The following is a description of a gene set: Estrogen-dependent nuclear events downstream of ESR-membrane signaling Human Gene Set: REACTOME_ESTROGEN_DEPENDENT_NUCLEAR_EVENTS_DOWNSTREAM_OF_ESR_MEMBRANE_SIGNALING studied in species Homo sapiens, and this is the list of marker genes: ELK1, BCL2, SRF, EGF, MAPK1, AKT3, AKT2, PTK2, HBEGF, CREB1, TGFA, FOS, CDKN1B, EGFR, AREG, AKT1, CCND1, MAPK3, EPGN, EREG, FOXO3, XPO1, UHMK1, BTC